Given this list of marker genes STAT6, CD28, HAVCR2, CDKN2A, MLH1, POLE, RHOH, IKZF3, MDM2 (NCBI Gene Id 84825), ITK, PMS2, BIRC3, MYC, FCHO1, NFATC2, SMARCAL1, SYK, MAGT1, FASLG, TTC7A, RASGRP1, ATM, PIK3R1, TNFRSF1B, XIAP, MALT1, FOXP1, CCND1, SH2D1A, ADA, CTLA4, NTHL1, MSH6, CHEK2, FAS, PTPRC, TP53, BCL10, CASP10, NBN (NCBI Gene Id 4683), DIAPH1, here is a description of the gene set: Human Gene Set: HP_NON_HODGKIN_LYMPHOMA species: Homo sapiens A type of lymphoma characterized microscopically by the absence of multinucleated Reed-Sternberg cells. Non-Hodgkin lymphoma